The following is a description of a gene set: Human Gene Set: HP_MALE_SEXUAL_DYSFUNCTION A problem occurring during any phase of the male sexual response cycle that prevents the individual from experiencing satisfaction from the sexual activity Male sexual dysfunction studied in species Homo sapiens, and this is the list of marker genes: NSMF, SPRY4, SMARCB1 (SWI/SNF related, matrix associated, actin dependent regulator of chromatin, subfamily b, member 1), FGF8, TACR3, HEXB, NR0B1, DNAJC6, LMNB1, HFE, TTR, FGFR1, SYNJ1, TNFSF4 (NCBI Gene Id 7292), KISS1, CDKN1A, LRRK2, HJV, KISS1R, BAP1, DUSP6, TERT, CCDC141, HLA-DRB1, ABCD1, SEMA3A (NCBI Gene Id 63232), PRKN, PARK7, HTRA2 (HtrA serine peptidase 2), CDKN2C, SMARCE1, COQ2, TAC3, PROKR2, BMP6, DCC, HS6ST1, PIK3CA, AR, HBB, ZNF365, PROK2, FGF17, IL17RD, UBAP1, CHD7, NDNF, PINK1, CDKN2B, ENSG00000288330, GUCY1A1, BMP2, TRAF7, CDKN1B, NHLH2 (nescient helix-loop-helix 2), SACS, ANOS1, SOX10, MEN1, SLC40A1, WDR11, GALC, NDP, AIP, SUFU, PIGA, CDH23, FLRT3, HESX1, NF2, PODXL, FEZF1, ATXN8OS, CACNA1G, CTSH, P2RY11 (purinergic receptor P2Y11), GNRHR, HLA-DQB1 (major histocompatibility complex, class II, DQ beta 1), VPS13C, SMO, IRF4, GNRH1, PDGFB, UCHL1, HAMP, RTN2, GPR101, FMR1, MOG, HCRT, TFR2, AKT1, SNCA